The following is a description of a gene set: Human Gene Set: GSE18791_CTRL_VS_NEWCASTLE_VIRUS_DC_1H_UP species: Homo sapiens from publication Zaslavsky E, Hershberg U, Seto J, Pham AM, Marquez S, Duke JL, Wetmur JG, Tenoever BR, Sealfon SC, Kleinstein SH (PMID 20164420) The dendritic cell (DC) is a master regulator of immune responses. Pathogenic viruses subvert normal immune function in DCs through the expression of immune antagonists. Understanding how these antagonists interact with the host immune system requires knowledge of the underlying genetic regulatory network that operates during an uninhibited antiviral response. In order to isolate and identify this network, we studied DCs infected with Newcastle Disease Virus (NDV), which is able to stimulate innate immunity and DC maturation through activation of RIG-I signaling, but lacks the ability to evade the human interferon response. To analyze this experimental model, we developed a new approach integrating genome-wide expression kinetics and time-dependent promoter analysis. We found that the genetic program underlying the antiviral cell state transition during the first 18-hours post-infection could be explained by a single regulatory network. Gene expression changes were driven by a step-wise multi-factor cascading control mechanism, where the specific transcription factors controlling expression changed over time. Within this network, most individual genes are regulated by multiple factors, indicating robustness against virus-encoded immune evasion genes. In addition to effectively recapitulating current biological knowledge, we predicted, and validated experimentally, antiviral roles for several novel transcription factors. More generally, our results show how a genetic program can be temporally controlled through a single regulatory network to achieve the large-scale genetic reprogramming characteristic of cell state transitions. Genes up-regulated in comparison of control conventional dendritic cells (cDC) at 0 h versus cDCs infected with Newcastle disease virus (NDV) at 1 h., and this is the list of marker genes: PRND, AP2A1, CHDH (choline dehydrogenase), TRIM67-AS1, WFDC10B, HFE (NCBI Gene Id 3077), GUCY1B2, HAO2, GSC, SPIB, DSC3, PARS2, PFN4, RUNDC1, ZNF557, CD5, HNF4G, ACAD10, HTR3C, PCDH17, TICRR, UGT3A1, SSR4P1, PROSER2-AS1, LINC01553, SEC24B-AS1 (SEC24B antisense RNA 1), ANKRD33, LINC00525, CELA1, FOXP4, RAET1E, CYP4B1, CBLN4, GS1-600G8.3, SKIC2, CRIP3, SYNGR4, RGS11, ZNF691, ARMC2, LIMD1-AS1, PARD6G (NCBI Gene Id 84552), CPVL-AS2, FOS, ENSG00000224090, C8A, LINC01530, MRPS31, MED12L, DIPK1C, KRTAP13-1, LINC00165, BRS3, LETR1, PTGDS, AGXT2, CSGALNACT1, FER1L4, DPEP1, BATF2, CD300LG, KAZALD1, P2RY13, MC2R, LGALS4, ZFP3, ZNF460, LYSMD3, CDO1, ZSCAN20, PITPNM2, SP8, ZNF850, CORO2B, SNAP25, PTPRU, CLEC2L, NHERF4, ZSCAN32, MOGAT2, SDK2, ARHGAP39 (NCBI Gene Id 80728, Rho GTPase activating protein 39), ADCYAP1, HGFAC, ERBB3, TLR7, KCNK2, ABTB3, TEX19, VSIG1, GALNT16, XDH, CYP3A7, SNX21, PLA2G2A (NCBI Gene Id 5320), IRGM, NCDN, BTBD2 (BTB domain containing 2), ZNF546, LMNTD2-AS1, C1orf74, PART1, ITM2A, ENSG00000255647, ZNF234, TTI2, FANCB, EVC2, WDR27, DNAJC9-AS1, EMID1, NAP1L5, NR5A1, HAND2-AS1, ENKUR, SLC66A1LP, BMP1, EXOC3L2, PAX7, FAM83E, SLC39A5 (NCBI Gene Id 378941), TNFRSF19, NKX6-3, MBD4, ASIC2, EFNA5, FOXH1, SDCBP2-AS1, COL4A3, SPATA17, ZFP62, OR6B1, LINC00656, JPH1, TMEM37, GSTA1, ZNF681, PTGDR2, KDF1, DNTT, SNAI3-AS1, IFNA14, CCDC116, TLR6, BTNL9, UNC13C, ATP8B5P, ZBTB9, MORN3, RTP4, GABRB3, LINC01102, SLC44A3, NIFK-AS1, TMEM95, LINC01465 (long intergenic non-protein coding RNA 1465), SNTG2-AS1, KLHL13, LSAMP, ZSCAN4, ZNF561, PTPN3, SLC35D3 (solute carrier family 35 member D3), WNT4, CKMT2, GJB4 (NCBI Gene Id 2708), IL25, OR5J2, GLYATL1, IL17RD, LAMA4, GALNT17, SALL3 (spalt like transcription factor 3), TTLL11, PRSS54, ZNF302, CYP39A1, MZF1-AS1, TDRD12, GET1, PRKAG3, DAB1